The following is a description of a gene set: Genes from the brain cancer stem (cancer stem cell, CSC) signature. species: Mus musculus from publication Harris MA, Yang H, Low BE, Mukherjee J, Guha A, Bronson RT, Shultz LD, Israel MA, Yun K (PMID 19074870) Human Gene Set: HARRIS_BRAIN_CANCER_PROGENITORS The recent identification of cancer stem cells (CSCs) in multiple human cancers provides a new inroad to understanding tumorigenesis at the cellular level. CSCs are defined by their characteristics of self-renewal, multipotentiality, and tumor initiation upon transplantation. By testing for these defining characteristics, we provide evidence for the existence of CSCs in a transgenic mouse model of glioma, S100beta-verbB;Trp53. In this glioma model, CSCs are enriched in the side population (SP) cells. These SP cells have enhanced tumor-initiating capacity, self-renewal, and multipotentiality compared with non-SP cells from the same tumors. Furthermore, gene expression analysis comparing fluorescence-activated cell sorting-sorted cancer SP cells to non-SP cancer cells and normal neural SP cells identified 45 candidate genes that are differentially expressed in glioma stem cells. We validated the expression of two genes from this list (S100a4 and S100a6) in primary mouse gliomas and human glioma samples. Analyses of xenografted human glioblastoma multiforme cell lines and primary human glioma tissues show that S100A4 and S100A6 are expressed in a small subset of cancer cells and that their abundance is positively correlated to tumor grade. In conclusion, this study shows that CSCs exist in a mouse glioma model, suggesting that this model can be used to study the molecular and cellular characteristics of CSCs in vivo and to further test the CSC hypothesis., and this is the list of marker genes: MGP, COL6A2, GJA1, DDC, VXN, TMEM212, OPCML, KCNA4, SCG5, PAPSS2, SHISA2, NINJ2, MIA, ARHGAP29, SRPX2, CYTL1, CREBRF, AOX1 (NCBI Gene Id 316), WNT5A, GPR17, FOXA3, KAZALD1, LARP6 (NCBI Gene Id 55323), CASP4, S100A4, BGN, BFSP2, DHRS3, ERVFRD-1, TEAD1, SCG3, PLPPR4, FOXC2, LGALS2, MLIP, PID1, CAPG, CAV1, ARHGAP6, COL6A1, VWC2, ENPP6, S100A6